Given this list of marker genes MGARP, VWA5A, SLC25A39, TMEM129, OGFOD2 (2-oxoglutarate and iron dependent oxygenase domain containing 2), ANAPC5 (NCBI Gene Id 51433), SLC25A20, CCND2, VPREB3, REXO2, PLAC8, DIAPH2, SNRNP27 (NCBI Gene Id 11017), CACNG4, ORC5, FBF1, SLFN13, UBALD2, RIOX1, GOLT1B, FBXO9, MRPL44, CBX6, SHMT1, SLC17A9, CLNS1A, RIPK2, SLC6A14, TMEM268, MMP7, PIP, MICOS13, PHGR1, ZNF235, MRPL39, FUOM, KIF4A, ARL16, PROSER1, TMEM100, CLEC1B (NCBI Gene Id 51266), ZNF703, TIMELESS, RPL3L, PIGH, SMARCA2, NEK7, SELENOP, IPPK, FZD8, NME3, RALBP1, DTL, PDLIM4, CCN3, TM4SF4, TRMT10B, CXCR4, PAPPA, OXLD1, MRPS2, TRIM25, VHL, RNF181, TMEM121, LSM1, C19orf12, DLG3, CUEDC2, MFAP2, ACOT13, GNE (NCBI Gene Id 81868), TUBG2, BTK, RNF34 (NCBI Gene Id 96268), CHI3L1, PKP3, PRELID1, HEBP1, C6orf62, TIAL1, DOLPP1, TADA2A, COA6 (cytochrome c oxidase assembly factor 6), ANKRA2, CDK20, RMND1, RPL39, CEP19 (centrosomal protein 19), CASP6, GLIPR1L2, CIBAR1, ANKRD54, TDRD3, SLC2A1, TMEM115, ABHD10 (abhydrolase domain containing 10, depalmitoylase), AKAP8, SASH3 (SAM and SH3 domain containing 3), ZNF467, SIDT2, LINGO1, NSMCE3, QSER1, TESK2, GORASP1, CSTB, GCNT1, RD3, LPAR2, LUC7L, HMGCL, NKX2-4, PSMC2, COPS6, LPGAT1, ZYG11B, DNAJC10, OASL, SLC12A5, RRP7A, ILK, AIRN, UBA2, MRPS26 (NCBI Gene Id 81568), POLR2H, IFT172, RPA1, SMARCAL1, RESP18, TFDP1, CYBC1, PIMREG, CD79B, ADCY7, CHCHD7, NDUFB11, TUBB2A, KLHL9, TAF4, AIMP2, TNRC6A, PDK4, DOP1B, RHOD, TMEM54, CYSTM1, PTCRA, MRPS24, ECHDC3, HCFC1R1, ERCC6L, PMM2, OCIAD1, PES1, C19orf48P (chromosome 19 open reading frame 48, pseudogene), GPR146, TAX1BP3, DUSP6, AVP, FTSJ1, NUCB2, COMMD4, GNG10, KANSL2, CDK4, STAT2, STOML2, UBTD1 (NCBI Gene Id 80019), MIS18BP1, DGAT1, RGL2, PLPP2, APOD, ANXA8, IFIT2, FRS3, GRB7, NONO, MLYCD, FAU, SLCO1A2, HTRA2, UGT2B4, FOXP3, HLX, PACS1, RELL2, TFB2M, ACY1, ELOC, MITD1 (microtubule interacting and trafficking domain containing 1), IFT70B, SCAND1, GADD45GIP1, TCTE1, GET4, COL6A3, KEAP1, UPF2, here is a description of the gene set: Human Gene Set: GSE17721_CTRL_VS_GARDIQUIMOD_2H_BMDC_UP studied in species Homo sapiens from publication Amit I, Garber M, Chevrier N, Leite AP, Donner Y, Eisenhaure T, Guttman M, Grenier JK, Li W, Zuk O, Schubert LA, Birditt B, Shay T, Goren A, Zhang X, Smith Z, Deering R, McDonald RC, Cabili M, Bernstein BE, Rinn JL, Meissner A, Root DE, Hacohen N, Regev A (PMID 19729616) Genes up-regulated in comparison of control dendritic cells (DC) at 2 h versus those stimulated with Gardiquimod (TLR7 agonist) at 2 h. mouse primary BMDCs were stimulated with tlr ligands and gene expression changes were profiled on Affymetrix arrays